The following is a description of a gene set: Any process that results in a change in state or activity of a cell or an organism (in terms of movement, secretion, enzyme production, gene expression, etc.) as a result of a lipid stimulus. Human Gene Set: GOBP_RESPONSE_TO_LIPID species: Homo sapiens, and this is the list of marker genes: SOD2, PDCD7, ZBTB7A, SOX10, AANAT, C2, SLC12A3, WNT11, CPT1A, FOSB, CASP1, TACR1, TLR4, CYP27B1, FDX1, GLDC, CACTIN (NCBI Gene Id 58536), SIGIRR, INSIG2, CSF2RB, AARD, CD274, SCNN1A, MYD88, NODAL, COL1A1, URI1, PDX1, KLRC4-KLRK1, ETNPPL (NCBI Gene Id 64850), FOXO3, SCN11A, NFKB1, GBP5 (NCBI Gene Id 115362), PF4V1, ESR2, SLIT3, OTUD5, HDAC6, TRIM41, PPP5C, AHR, SSTR4, BCR, GIT1, CARD8, PTPN6, ADAM17, TIE1, EFNB2, SH3RF1, IL6 (NCBI Gene Id 3569), CAV1, PTGDR2, GPBAR1, MTDH, PHB2, PARP1, ALPL, CARD16, HSD17B2, DEFB104B, YES1, YAP1, NRIP1, VPS18, LY96, IRF8, PTK2B, ENDOG, SLC11A1, NOS3 (nitric oxide synthase 3), INHBB, KLF4, NOS1, AKAP12, MLC1, SIRPA, TXNIP, CXCL6, POR (cytochrome p450 oxidoreductase), DDX17 (NCBI Gene Id 10521), TNIP2, DEFB114, ATP4B, ABCA3, TAT, CYP19A1, SELE, ZNF683, EEF2 (eukaryotic translation elongation factor 2), VCAM1, DDIT4, SLC34A1, SYK, KLRK1, VPS11, IL12A, HNRNPA0, LILRA2, FGFR2, CCL21, ADIPOQ, MAPK1, MYOG, EDNRB, TBXAS1 (thromboxane A synthase 1), TNFRSF1B, SIRT1, KAT5, REN, CD55, PID1, HTR5A, GNAS, CRH (NCBI Gene Id 1392), DSG2 (NCBI Gene Id 1829), FMO1, IL36G, IL10RA, RPS6KB1, FOXP1, UBR5, SERPINE1, PTGER1, PELI1, NKX3-1, CALR, HDAC1, HSF1, MYB, IL24, NR1D1, RORB, CD4, FOXA1, AXL, GATA1, NCOA4, PAQR7, IL1F10, NAGLU, GH1, JUND, P2RY4, GBA1, HOXA10, TNIP3, ADAM9, PTCH1, RORC, RXRB, LILRB2, GATA4, NR2E3, PPARG, LPAR1, ALAS1 (NCBI Gene Id 211), LOX, FFAR3, MAP2K1, OXT, SOX9, HTRA2, MAP2K3, PAF1, CRY1, NFKBIA, RUVBL2, IGFBP2, MAP1B, CNOT2, CTSG, FOXO1, ABCA2, RORA, PYCARD, EP300, IRGM, GRIA1, NR4A3, TWF2, AKT1, PIAS2, MIR766, TRIM68, CX3CL1, LTA, WNT9A, FBXO32, NCOR2, COMT, LATS1, NCOA3 (nuclear receptor coactivator 3), SPON2, PTH, UBE3A, TCF21, CD68, FOXP3, KDM4C, CREBRF (NCBI Gene Id 153222), HOXA13, TGFBR3, RARG, TESC, RPL13A, CALCR, PTK6, USP26, IGF1, PRKCA, FBP1, WDR83, CYP7A1, SOCS2, UFL1, WNT5A, MIR125B1, MYOD1, TRIM5, TBXA2R, LMO3, NR1H3, ZFP36L2, ATP1A2, WNT10B, XIAP, IGF2R, PMEPA1, TAC1, PRKAA1, ABL2, LCAT (NCBI Gene Id 3931), CCL2, KANK2 (KN motif and ankyrin repeat domains 2), PPM1E, LRAT, CPN1, NR2E1, AKR1C3, COL6A1, VPS54, AVP, SNW1 (NCBI Gene Id 22938), FOXH1, SELP, NR2F2, CDK19, TRIP4, TNFAIP3, MIF, NTRK3, RET, REST, DUSP1, SSTR2, HPGD, STRN3, S100A14, ZC3H12A, TAF1, PENK, ALAD, IL23R, SMAD6, WNT5B, STC2, UFM1, PLCG2, ATP1A3, GNRH1, CAPN2, SNRNP70, CYP24A1, LCN2, PAK1, ALDH1A2, EPO, IRAK4, MBD3, APOA4, PTGDR, TCF7L2, MSX2, XBP1, GBP3, CASP7, MSTN, GPER1, PARK7 (Parkinsonism associated deglycase), MAP2K7, MDM2, YWHAH, PTGFR, FKBP4, THBS1, GHSR, DEFA6, SLC7A5 (NCBI Gene Id 8140), FKRP, HSD11B2, SGK1, IRS1, LACRT (NCBI Gene Id 90070), PPP1R9B, TLR5, DSG1 (desmoglein 1), IL1RN, FFAR1, NLRP3, SMAD2, PCK1, SCNN1G, EFNA5, BMP6, MAPK14, GDAP2, TIFAB, CRYAB, BDKRB1, TNFSF4, BCHE, CBX3, UPF1, TRIB1, MPO (myeloperoxidase), BPI, BTG2, KCNK10 (NCBI Gene Id 54430), ADCY2, ERRFI1, SKP2, SPP1, SNCA, TGFB3, PRPF8, SCGB2A1, TNFRSF11A, HMGA2, NCOR1, ZDHHC7, BRINP2, CD86, IRAK3 (NCBI Gene Id 11213), NDUFA13, FGFR4, ZNF35, ZFP36L1, NFKB2, BMP7, ACSL1, HMGB2, ENO2, MGST1, IDO1 (NCBI Gene Id 3620), ERBIN, PLPP1, JAK2, PTPN11, FAM210B, SMYD3, NOS2, LRP8, CFLAR, ELANE, CASP8, HDAC5, MIR182, CYBB, GJB6, CD96, PAX2, ROCK2, ACP5, ZFP36, TICAM1, MIR92A1, IRAK1, DAG1, ADCYAP1R1, F2R, GSTP1, LPL, GATA2, NUGGC, TRIM24, PRMT2, PTGIR (prostaglandin I2 receptor), SSTR5, BRINP1, HSPA8, PTPRU, AKR1C2, TPCN2, ARPC1B, CCR5, ESR1, BOLA3 (bolA family member 3), OSBPL7, METTL21C, ADTRP, ACOD1, GPRIN3, MMP2, IL10, CD40, PLSCR4, PDE4B, MEF2C, MAPKAPK2, PAGR1, TACR3, NKX2-2, MN1, ANKRD13C, HSPA1A, PCK2 (phosphoenolpyruvate carboxykinase 2, mitochondrial), TAB2, ABCG1 (NCBI Gene Id 9619), LOXL1, CAT, MGST2, PKN1, FGF23, NR0B1, VPS4B, IL18, GRAMD1C, DAB2IP, GDAP1, PTGDS, HCN2, FBXO3, FZD4, GNAQ, USP8, FER, TRIM63, UBE2L3, MIR146A, MMP3, SCGB1A1, AIFM1, CAMP, PTPRC, CXCL5, RXRA, HEYL, WNT9B, OSR1, NPAS4, NPC1, SLC6A4, GHR, YY1, AKR1C1, MIR20A, NFKBIL1 (NCBI Gene Id 4795), HAND2, ABCB1, NCF1, TGFBR1, SREBF1, STRA8, ADCY3, BMI1, NOTCH1, MBD4, PGR, ZNF366, PRKCD, RAC1, CLOCK, PAQR8, CYP8B1, TICAM2, CYP1A1, CX3CR1, LANCL2, SLC5A5, EIF4E, GCH1, NTSR1, DUSP10, MRC1, HMGB1, GSK3B, IL1B, MIR17, UCN3, ATM, CCNA2, TRERF1 (transcriptional regulating factor 1), LBH, STAT5B, CCR7, CHMP5, GSTCD, AVPR1A, FFAR2 (free fatty acid receptor 2), CPS1, HDAC2, NR3C2, E2F1, DEFA3, ADCY1, SLC39A9, P2RX7, DDX54, MIR224, GSK3A, SELENOS, MIR140, KMO, AGL, MALT1, HOXB13, PCNA, PRDX3, NASP, NEFL, MIR21, CYBA, CD200, ARID5A, CST11, ITGAM, FECH, ANKRD1, MIR6869, PDCD1LG2, PLN, SOX30, ACER2, GPX1, UFSP2, LGALS9, IRAK2, RNF14, POU4F2, PTGER2, SCGB2A2, PLCB1, CREB1, THBD, PTK7, GPR83, IDH1, PPARGC1B, PRKN, CD38, NR3C1, KLF9, MAPKAPK3, IL12RB2 (NCBI Gene Id 3595), TRIM6, RNF6, RBP4, MT-ND3, CEBPA, XRN1, BCL10, TLR9, TGFB2, IL13, UCN, RAN (RAN, member RAS oncogene family), CTSH, SELENOW, H2AZ1, PDK3, POSTN, CDO1, VDR, CCL28, PHC1, CYP26B1, PDCD4, NCOA2, PLAA, STXBP1, ACSBG1, DIO2, CNOT9, CD6, CEBPE, NEDD4, GKN2, CARD17P, ATP1A1, HES1, GNAI1, NFKBIZ, DGAT2, GPR155, INHBA, BMAL1, LRP6, PRKD1, CALCOCO1, SCIMP, BRINP3, PHEX, CNOT1, ESRRA, MAPK8, BCL2, CAV3, SRD5A1, S100B, MSN, KMT2D, HSPA1B, LDOC1 (NCBI Gene Id 93489), FSHR, CDK12, MIR185, GNG2, ABCC8, TNF, FCAR, RIPK2 (receptor interacting serine/threonine kinase 2), RGS9, TSPO, FAM107A, PABPN1, CDKN2D, TNIP1, JUNB, CXCL8, LY86, TFAP4, PIM1, PIM3, ANKK1, WNT3, MIR223, CLDN1 (NCBI Gene Id 9076), WNT8B, ATP5F1A, DEFA1B, PRDX2, PRKAA2, GLB1, MIR187, TGFB1, PER1, LCOR, CTR9, DYNAP, AKR1C4, UCP3, SAFB2, XPO1, ITGA2, TREM2, GHRHR, MTAP, SLIT2, ABCA1, CSF2, KIF18A, ARNT2, CXCL9, RELA, NR2C1, MIR96, WNT7B, DEFA5, SRC, KDM3A, AQP1, KDM5D, ABL1, CYP26A1, CD80, CITED1, DEFA1, CEBPB, FIS1, IL36RN, ACR, NR1H4, DDRGK1, LIAS, SCARB1, CCND1, CA9, CLDN4, ADCY8, MGARP (NCBI Gene Id 84709), TLR2, MIR433, TFRC, IGFBP7, CD180, EZH2 (NCBI Gene Id 392834), CDC73, SHPK, CRY2, CDK4 (cyclin dependent kinase 4), FLT3, CMPK2, VIM, SLC10A3, IFNAR1, UCP1, PGRMC2, TYR, CCNB1, IL18BP, SPHK2, CAD, IL1A, PADI2, MBD2, GPLD1, RHOXF1, PTAFR, TGFBR2, LTF, MED1, GOT1, CRHBP, SCNN1D, HOXA11, SASH1, CFTR, TAF7, S100A7, GIPR, BGLAP, MEIOSIN, CYP7B1, ADCY5, IL37, MAPK3, B2M, TNC, HCK, CARM1, CCL19, DNAAF2, ADAM15, FASLG, FABP3, AKIRIN2, RARA, AKAP8, CNR2, LDLR, ESRRG, SLPI, PALM3, CASP9, MIR128-1, WNT3A, ISL1, ABCB4, ADCY6, HADHB, PLSCR3, TIRAP, HOXA9, MEST (mesoderm specific transcript), STC1, DNAAF4, ELK1, ZMIZ1, SMARCA4, GRAMD1A, LETMD1, HDAC3, OPRK1, PSPH, LYN, MMP15, CCL27, HAVCR2, ASS1, SNAI2, DEFB104A, MAP4K1, FES, SFRP1, KDM1A, CASP3, F7, ID3, IHH, RHOA, DKK1, EPHB2, OVCA2, PDE3A, STAT3, GNB1, BTK, LILRB1, DHH, GATA6 (NCBI Gene Id 2627), IL36A, TADA3, STK39, NOCT, SMARCD1, HOXD13, JUN, TBX1, RWDD1, MIR342, TRAF6 (NCBI Gene Id 7189), MMP8, DGKQ, TEAD2, SSTR1, IL12B, ESRRB, CXCL13 (NCBI Gene Id 115545), AREG, SCNN1B, SRR, PTGER4, FZD10, PTPN22, BAD, UMOD, ADH5, KL, FGF10, FOS, SMO, ANXA1, ASCL1, CSF3, UCP2, AQP3, WNT8A, TMEM161A, RXRG, SPI1, MIR142, PPARD, RBFOX2, TRIML2, HNRNPU, KRAS, SRD5A2, TMF1, GPX4, NR4A1 (nuclear receptor subfamily 4 group A member 1), PHB1, TBX2, MMP9, HNRNPD, LEP, GPX3, DEFB118, DAXX, IL36B, WNT6, MDK, GBP2, GRAMD1B, IL22, SP100, PDK4, NFE2L1, SCD, NCOA1, HMGCS2 (NCBI Gene Id 3158), GFI1, LITAF, PPARA, NOD2, DRD2, TP63 (NCBI Gene Id 8860), DNMT3A, EPHA3, CD14, PIK3CA, KCNK4, DDX5, SBNO2, CXCL10, S100A8, ACACA, SHQ1, P2RY6 (pyrimidinergic receptor P2Y6), WNT7A, PRKCE, LIPA, CSN1S1, ABHD2, CBL, NLRP7, LBP, DEFA4, DDX18, MICB, RAMP3, GPI, RBBP7, DAB2, LTK, WBP2, CALM3, UBA5, KCNK2, GABRB1, LCN10, EGLN2, STAP1, PMVK, SERPINF1, HOXA2, OR51E2, CASR, TRIM16, ADAMTS13, ASXL1, ILDR1, SAFB, AXIN2, NFKBIB, FZD7, CES1, CCDC62, CARD9, IRF3, WNT2 (NCBI Gene Id 7472), SST, SRARP, FOSL2, CTNNB1, EDN1, PPBP, CD36, BRCA1, AICDA, CCL3, NQO1, TRIM25, AR, BCL2L11, ZNF764, PF4, TFPI, POU4F1, RPS6KA3, INSIG1, ZNF703, EGFR, KCNJ8